Given this list of marker genes ST6GALNAC1, PSMB10, XBP1, PTGES, GLRX, ST14, KRT7, CLINT1, COPB2, WNK2, SORL1, FAM3C, CTSC, PLEKHS1, PGD, IGFBP3, BPIFA1, AGR2, A4GALT, GOLM1, FAM114A1 (NCBI Gene Id 92689), SLC25A39, SERPINB4, PODXL, SLC5A8, CD82, FUT6, MSMB (NCBI Gene Id 4477), CARHSP1 (calcium regulated heat stable protein 1), CMPK1, MUC5B, CSTB, ATP12A, MUC4, SAT1, GNA15, VMO1, CXCL6, ALDH2, FKBP11, LRRC26, OAT, SERINC2, S100P, FUT3, SLC12A2, SLC4A4, NDRG2, SLC26A2 (solute carrier family 26 member 2), SCNN1B, UGP2, KLF4, BPIFB1, TNFSF10, BIK, LINC00342, TMPRSS4, CXCL1, RAMP1, CHL1, CAPN13, RHOV, GALNT6, CRABP2, MDK, STEAP1, CST3, DHRS9, OAS1, SPDEF, RND3, SLC31A1, CYP2F1, MYDGF, FUT2, NHERF2, AK2, RHOC, PDLIM5, S100A16, DNAJC3, RPL18A, C3, STAP2, SDF2L1, SLPI, LCN2, PLAAT4, UAP1, PKM (NCBI Gene Id 8127), NIBAN1, SRD5A3, ADGRF1, RER1 (NCBI Gene Id 11079), LGALS9, CYBA, PSCA, TIMP1, CRACR2B, TGM2, MUC16, C15orf48, CP, SORD, HS3ST1, PAM, VTCN1, GMDS, B4GALT4, RDH10, MARCKSL1, MGST1, BACE2, TSPAN8, ARL1, AKR1C1, COMTD1, GSTA1, ASS1, AKR1C3, WFDC21P, DNAJC12, ECE1, FAM3D, REEP3, KDELR2, IFI16, LGALS3, CHP2, CTSB, CXCL17, PIGR, B3GNT3 (UDP-GlcNAc:betaGal beta-1,3-N-acetylglucosaminyltransferase 3), GLIPR2 (NCBI Gene Id 64148), ST6GAL1, RRBP1, SLC6A14, PDIA4, FBXW5, NANS, CYP2J2, SLC15A2, BZW1, WFDC2, SERPINB3, NUCB2, P4HB, GTF3C6, here is a description of the gene set: species: Homo sapiens Human Gene Set: TRAVAGLINI_LUNG_GOBLET_CELL from publication Travaglini KJ, Nabhan AN, Penland L, Sinha R, Gillich A, Sit RV, Chang S, Conley SD, Mori Y, Seita J, Berry GJ, Shrager JB, Metzger RJ, Kuo CS, Neff N, Weissman IL, Quake SR, Krasnow MA (PMID 33208946)